The following is a description of a gene set: species: Homo sapiens Human Gene Set: HNF4_DR1_Q3 Genes having at least one occurrence of the motif TGAMCTTTGNCCN in the regions spanning 4 kb centered on their transcription starting sites. This matches the HNF4A transcription factor binding site V$HNF4_DR1_Q3 (v7.4 TRANSFAC)., and this is the list of marker genes: WRAP53, HOXD3, PRR14, NDUFS1, GOLGA4, PRDM16, SHFL, TTI1, MYH10, ZIC4, TNFRSF12A, TP53, SEC16B, DNAJA2, ARHGEF7, F12, SHF, PIEZO2, LYSMD1 (NCBI Gene Id 388695), FAM170A, NPSR1-AS1, NPHP4, FOXA3, INSR, ZNF436-AS1, NR4A3, PRDM1, PTCHD4, USP37, PFN1, IGF2BP1, GATA4, MIEF1, HIBADH (NCBI Gene Id 221893), DRC3, MRPL11, MED8, SLC23A3, ARHGEF12, MIR22HG, ID1, ANGPTL8, RNF144B, WNT3, GTF2I, ATN1, CCL15, DMD, ADAMTS19, C14orf132, GBF1, SGK1, TREX1, RBMS1, NEUROG2, NUDT22, MASP2, SHMT1, TREH, SMYD5, EXOSC7, HSPE1, GDNF, YBX2, DIDO1, F10, LRP1, DNAJC22, HSD17B8, MAP3K11, KLC4, ATP1B1, SLC34A1, CDX1, ASXL1, IRX6, FKBP5, MSX1, MICAL2, POLD4, CLCN2, SLC26A6, NUDCD1, SENP2, PURA, MPL, PGF, GRK5, HOXB6, C2CD2L, ZNF644, FBLN1, IYD, LMO3, EIF4EBP2, MLEC, SCNM1, MARK2, SMOC1, PAN2, USP12, HAGH, UBE2K, GUCY2C, PAX7 (NCBI Gene Id 5081), MALL, PLPPR1, VWCE, DUSP3, PAK4, BPIFA2, ZFHX3, BIN3, PLEKHG6, SRSF6, SPRY4, TCAIM, PDLIM7, TOMM70, WDR81, IP6K2, PFKFB1 (NCBI Gene Id 5207), TTR, PRKCSH, ZPBP2, NR2F6, STMN2, USH1C, SYMPK, TCN2, SLC39A5, SETD2, RNF183 (ring finger protein 183), PEX16, TLK2, KLK6, AIF1L, TRPT1, POU5F1, KCNK10, DNAJB12, TOM1L2, PRMT1, SOD1, NET1, FAHD1, EFEMP1, TTYH2, PIPOX, FOXA1, POLR2H, MTTP, ERBB2, SPSB2 (NCBI Gene Id 84727), LRRN1, PPP1R14D, MRPL2, VTA1, NR2C1, ATAT1, PABPN1, PRKCD, ZNF436, ITGA1, AHCYL1, OTC, ZBTB12, JMJD1C, SEC22B, MOBP, ENO3, PICALM (phosphatidylinositol binding clathrin assembly protein), MTMR4, U2AF1L4 (NCBI Gene Id 8176), NHERF4, PTMS, PELO, MAP3K20, CLDN10, GPRC5B, SELENOM, NDST2, RPRD1B, MLST8, PKLR, SOX5, EEF1B2, SEMA3B, TIMELESS, ESRRA, CLRN3, MPC2, PAPLN, ZBTB45, PLEC, CDK16, DPF3, DCHS1, CKAP4, LHPP, FABP1, SNAP25, HOXA5, MLLT6, ZNF516-DT, UBE2R2, OVOL1, LAMP2 (NCBI Gene Id 3920), LMAN2, PDZK1, LMOD3, EGR3, PARP6, DCTN2 (NCBI Gene Id 1640), ZDHHC3, GALK1, FXYD1, ODAD3, PRR7, KIF6, GTF3C2, EFNB3, RREB1, CRABP2, PRODH2, SS18, ADGRA2, ATXN7L2, SAMD14, TBPL1, AGPS, PSMF1, SZT2, CLCNKA (chloride voltage-gated channel Ka), RTP3, PAK1IP1, TLE1, IFFO1, LGI4, SCAMP3, NR1H3, DCTN1, PTPRG, HOXA3 (homeobox A3), SCN1A, SNAI1, RAB5C, CNOT9, KCNE5, CNTFR, CKMT1B, ZBTB40, ERBB3, PRRX2, HSPD1, FGFR3, CUTA, FAM20C, LRRN2, LCAT, PNPLA2, SLC25A35, CSF2, AP1B1 (adaptor related protein complex 1 subunit beta 1), DAB2IP, PPARGC1A (NCBI Gene Id 10891), PTH1R (parathyroid hormone 1 receptor)